The following is a description of a gene set: Human Gene Set: HP_ABNORMAL_FETAL_PHYSIOLOGY species: Homo sapiens Any functional anomaly of the fetus. Abnormal fetal physiology, and this is the list of marker genes: TRAK1, TMCO1, NDN, NSD1, UQCRFS1, COX15, FGFR3, USP7, NDUFAF1, MT-ND2 (mitochondrially encoded NADH:ubiquinone oxidoreductase core subunit 2), NDUFAF4, ALDH7A1, SLC18A3, PPP3CA, NSD2, CACNA1A, PAX7, NELFA, MYOD1, PHOX2B, HSPG2 (heparan sulfate proteoglycan 2), GLE1, UNC45B, NDUFS4, SCN8A, ODC1, CHUK, NAA10, COL6A3 (collagen type VI alpha 3 chain), DMPK, GBE1, DNMT3A, SLC6A9, ATP1A2, CDK19, DALRD3 (DALR anticodon binding domain containing 3), GABRB2, FOXG1, MYCN, KBTBD13 (kelch repeat and BTB domain containing 13), GBA1, NDUFAF5, TOR1A, GGPS1, ABCC6, SCN1A, TRPV4, NECAP1, SLC25A26, ABCD4, NDUFA10, DOK7, ACTL6B, KIF21A, ENPP1, B3GLCT, IFT56, NUS1, KLHL40, ATP8B1, FOXRED1, PREPL, MYF6, TPM2, VPS13B, FILIP1, AARS1, SYNGAP1, TUBA1A, CHRNA1, MYPN (NCBI Gene Id 84665), KCNC2, SNORD115-1, CLPB, OSTM1, TAF6, TMEM126B, CTBP1, DOCK6, SMN1, MT-ND3, NIPBL, GOSR2, CLTC, PPM1B, CDC42BPB, GABRA5, GFPT1, NDUFB9, CPLX1, WDR62, CELF2, ERCC5, SPEN, DHCR7, TRIP4, SLC25A1, PIGA, HACD1, SLC25A19, TBCK, GABBR2, MKRN3, NDUFB3, GPKOW, AP1S2, SNUPN, KIF5C, SCN3A, FZR1, FGF12 (NCBI Gene Id 2257), DHDDS, RYR1, NUBPL, CNKSR2, ABCB4, ADCY6, CHAT, NDUFB11, EXOSC9, TIMMDC1, GRIN2D, COL6A2, UBA1, LMOD3, NALCN, PLPBP, PIGS, PTRH2, DPAGT1, FXR1, ALG9, IKZF1, FKBP14, NEB, SNRPN, ATP1A3 (NCBI Gene Id 95633), CCDC174, LRPPRC, MUSK, USP18, RAI1 (NCBI Gene Id 6600), MYH3, NDUFS1, CPSF3, SHQ1, FLII, KCNA2, SCN4A, VAMP1, PARS2, PRUNE1, HCN1, SLC1A2, EEF1A2, NDUFS8, KCNB1, TNNC2, CRPPA, KCNQ5, MYL2, SOX10, BICD2, SON, ITGA7, MAP3K20, EMC10, AGRN, NFASC, SLC13A5, TRAIP, PWRN1, NDUFS7, PGAP2, SLC2A1, PLOD1, SNAP25, OCA2 (OCA2 melanosomal transmembrane protein), MPZ, H4C3, PEX3, ALG8, NDUFA11, NDUFA1, AFF2, PHGDH, RAD21, DNM1, ADGRG6, ZMPSTE24, PEX19, COL25A1, SYT2, AP3B2, RIPK4, SZT2, NDUFB10, SNORD116-1 (small nucleolar RNA, C/D box 116-1), EBF3, NPAP1, COX11, MYL1, CTCF, CHRND, ASNS, MAGEL2, NUP88, FGFRL1, HERC2, IPO8, PACS2, CACNA1B, MT-ND1, ZBTB42, NDUFV1, SLC3A1, BRD4, CAMKMT, EXTL3, MYMK, GNB2, COL13A1, SMC3, NDUFS6, NEXMIF, RPL11, SLC16A2 (solute carrier family 16 member 2), RET (NCBI Gene Id 5979), SMC1A, SYNE1, GLDN (NCBI Gene Id 342035), COL6A1, DPYSL5, COL12A1, DNM2, ATP6V1A, LMNA, DEAF1 (NCBI Gene Id 105376508), MYO9A, IGF2, NAA20, CAMK2B, YWHAG, PIGG, NDUFS2 (NADH:ubiquinone oxidoreductase core subunit S2), GLRB, NDUFS3, ERGIC1, ERBB3, RAPSN, CHRNG, IQSEC2, IL2RB, SCYL2, BIN1, ALG14, PSAT1, ZC4H2, ACTA1, CNTN1 (NCBI Gene Id 1272), ASCL1, IGHMBP2, BUB1, PEX2, NDUFA6, LETM1, IL1RN, FBXO28, DPH5, UBA5, GMPPB, KLHL41, MEGF10, NDUFAF8, GABRG2, NEK9, SLC5A7, NDUFAF3, DNA2, TPM3, SYNJ1, STX5, SELENON, SLC38A3, ASCC1, HDAC8, NDUFV2, PWAR1, CNTNAP1, CACNA2D1, MYT1L, DNM1L, NUP188, ATAD3A, POLR2A, WWOX, H19, MAP3K7, TSFM, NTRK2, NDUFAF2, CYFIP2, CRELD1, CCDC47, LGI4, MTMR14, GABRA2, CHRNE, MTM1